Given this list of marker genes C5AR1, RAB11B, CD36, IFNGR1, APP, LRP4, RAB5A, LRPAP1, IDE, ITGB2, CLU, MIR1908, CLTC, IFNG, APOE, MSR1, HMGCR, ITGAM, SYK, TTPA, INSR, MARCO, SREBF2, PLA2G3, ROCK1, C3, RAB11A, SRF, LDLR, IL4, CYP51A1, LRP2, TREM2, MYOCD, TNF, IGF1R, TYROBP, MIR34A, LRP1, MME, PICALM, ABCA7, here is a description of the gene set: Human Gene Set: GOBP_AMYLOID_BETA_CLEARANCE The process in which amyloid-beta is removed from extracellular brain regions by mechanisms involving cell surface receptors. studied in species Homo sapiens